Given this list of marker genes En1 (engrailed 1), Kdm2b, Gbx2, Hes1, Hes3, Fgf8, Ssbp3, Wnt1, Lrp6, here is a description of the gene set: Mouse Gene Set: GOBP_MIDBRAIN_HINDBRAIN_BOUNDARY_DEVELOPMENT The process whose specific outcome is the progression of the midbrain-hindbrain boundary over time, from its formation to the mature structure. The midbrain-hindbrain domain of the embryonic brain is comprised of the mesencephalic vesicle and the first rhombencephalic vesicle at early somitogenesis stages. species: Mus musculus